Given this list of marker genes AQP7 (NCBI Gene Id 91114), AQP9, here is a description of the gene set: Reactome Pathway: Transport of glycerol from adipocytes to the liver by Aquaporins part of: Aquaporin-mediated transport Triglycerides stored in adipocytes are hydrolyzed to yield fatty acids and glycerol. The glycerol is passively transported out of the adipocyte and into the bloodstream by Aquaporin-7 (AQP7) located in the plasma membrane of adipocytes. Glycerol in the bloodstream is passively transported into liver cells by AQP9 located in the plasma membrane of hepatocytes. Once inside the liver cell the glycerol is a substrate for gluconeogenesis. studied in species Homo sapiens